Given this list of marker genes FSIP2, DNAH7, ARMC2, CCDC146, DZIP1, STRC, CFAP70, DNALI1, DNAH10, DRC1, CFAP69, CFAP65, WDR19, USP26, AK7, CCDC34, AKAP3, TTC21A, DNAH17, QRICH2, CCIN, CFAP251, DNAH2 (NCBI Gene Id 57637), BRWD1, CT55, DNAH1, CFAP61, DNHD1, FKBP6, AURKC, CYLC1, STK33, SPEF2, LRRC23, SSX1, IFT74, CFAP43, SPACA1, CFAP74, TTC29, CFAP47, CFAP91, CATSPER2, CATIP, DNAH8, CFAP58, CFAP44, KCNU1, here is a description of the gene set: Abnormal sperm tail morphology species: Homo sapiens Human Gene Set: HP_ABNORMAL_SPERM_TAIL_MORPHOLOGY A structural abnormality of the sperm tail.